Given this list of marker genes SELENOT, TXNRD1, TXNRD3, GLRX2, P4HB, QSOX1, GFER, DNAJC10, TMX4, IFI30, PDIA4, TXNDC5, TXN2, TMX2, SESN2, PCYOX1 (prenylcysteine oxidase 1), PDIA5, PCYOX1L, TXNDC12, TXNDC8, PDIA3, SQOR, TXNRD2, NXN, TMX3, QSOX2, GLRX, SUOX, TXNL1, SELENBP1, SUMF1, TXNDC17, CLIC3, GSR, TXN, SCO2, STAB2, MSRB1, TMX1, PGK1, PDIA6, MSRB2, GSTO2, GSTO1, DLD, ERO1B (endoplasmic reticulum oxidoreductase 1 beta), CHCHD4, CCS, MSRA, ERO1A, PDIA2, MSRB3, TXNDC2, STAB1 (stabilin 1), COA7, SRXN1, here is a description of the gene set: Human Gene Set: GOMF_OXIDOREDUCTASE_ACTIVITY_ACTING_ON_A_SULFUR_GROUP_OF_DONORS Catalysis of an oxidation-reduction (redox) reaction in which a sulfur-containing group acts as a hydrogen or electron donor and reduces a hydrogen or electron acceptor. species: Homo sapiens